The following is a description of a gene set: studied in species Homo sapiens Human Gene Set: GOBP_ANTEROGRADE_DENDRITIC_TRANSPORT The directed movement of organelles or molecules along microtubules from the cell body toward the postsynapse in dendrites., and this is the list of marker genes: KIFAP3, STAU1, KIF5C, FLOT2, KIF5A, KIFC2, KIF17, RAB17, KIF5B, STAU2, KIF3B